Given this list of marker genes ZNF708, IRF2, GTF2H4, CDK2AP1, ABCD2, YWHAH, SNX24, TMEM60, ATP6V1A, STK26, ARHGEF6, INO80D, BORCS8, B3GALNT1, HEATR5A, RTN4, CD36, RNASE4, HMGA2, ATP6V1C1, METTL27, GPSM2, HPRT1, TMEM37, SKA2, TENT5A, NRP1, EIF3K, DLGAP5, CDT1, FOXO3, GPX3, TSPAN13, RASSF3, WIPF1, CASP8AP2, PHF14, SH2D3C, SHCBP1, SULF2, MED18, GNPDA2, MAPRE2, SLC41A3, CACUL1, SLC16A7, PEX3 (NCBI Gene Id 8504), YIPF6, CDKN2C, PANK1, GATC, PLEKHM1, NUCKS1, CEP44, MEF2A (NCBI Gene Id 4205), TMX4, FAM76A, TMEM135, UHRF2, GMNN, FBLIM1, RAD51AP1, GBA1, PSENEN, SASS6, NIPAL3, NOSTRIN, ANXA7, RBL1, RSF1, RBM15, METTL18, PLSCR4, ERMP1, RTF1, RBM43, GRAMD1B, ST3GAL5 (NCBI Gene Id 8869), CENPH, NCOA3, NUDT1, ANP32E, RDH10, TROAP (NCBI Gene Id 10024), RCBTB1, DRG1, LEPROTL1 (leptin receptor overlapping transcript like 1), MZT2B, CDCA5, C3orf70, PHKA2, HINT1, LRP1, RPL7A, PTP4A2, GABRR2, TPD52, EIF4B (NCBI Gene Id 55378), FBXW11, DIAPH3, C9orf85, SARS1, MAP3K5, COL14A1 (NCBI Gene Id 7373), ENC1, PADI2, IFT81, C2CD5, RAB40C, KIAA1143, GCNT1, SMARCAD1 (NCBI Gene Id 7303), MXD4, PDE7A, SUV39H1, FAM204A, ZNF496, DALRD3, CYP4F3, DRAM2, KIZ, SLCO4A1, CCDC47, AASDH, GCC2, OSBPL8, PALD1, MFSD12, NFATC2, SFT2D1, MPP1, TEC, ADSS2 (adenylosuccinate synthase 2), MYO1E, CBLB, NAP1L1, SNRNP25, RPL22L1, RCBTB2, ARHGAP19, HP1BP3, DYRK1A, HPF1, AGMO, FCHSD1, AKAP10, ANAPC1, CYP27A1, TRMT1, NDUFS2, FXYD5, ACD, EIF4A2, CD300C, CLIC4, CCR5, CHEK2, ARHGAP18, RBM41, DNASE1L1, DIPK1A, CCNDBP1, ARF6, CCR2, ACP6, SMIM30 (small integral membrane protein 30), ITGA6, FYN, CENPO, RHOBTB3, STRBP, PHF7, RGS18, CCND1, NCEH1, TFDP2, ZFAND4 (NCBI Gene Id 93550), BLTP3B, MIS18A, FAM107B, KDM2B, NUSAP1, CENPK, PRR11, ERCC6L, C1orf21, TNS3, H3C4, SELENOM, DGKZ, CCDC66, MTFR2, CREG1, TTC3, UBN1, EIF2D, POLG2, ATF6, MELK, ZNF467 (NCBI Gene Id 168544), here is a description of the gene set: studied in species Homo sapiens Human Gene Set: GSE24726_WT_VS_E2_2_KO_PDC_UP from publication Ghosh HS, Cisse B, Bunin A, Lewis KL, Reizis B (PMID 21145760) Genes up-regulated in plasmacytoid dendritic cells: wildtype versus TCF4 knockout. The interferon-producing plasmacytoid dendritic cells (PDC) share common progenitors with antigen-presenting classical dendritic cells (cDC), yet they possess distinct morphology and molecular features resembling those of lymphocytes. It is unclear whether the unique cell fate of PDC is actively maintained in the steady state. We report that the deletion of transcription factor E2-2 from mature peripheral PDC caused their spontaneous differentiation into cells with cDC properties. This included the loss of PDC markers, increase in MHC class II expression and T cell priming capacity, acquisition of dendritic morphology and induction of cDC signature genes. Genome-wide chromatin immunoprecipitation revealed direct binding of E2-2 to key PDC-specific and lymphoid genes, as well as to certain genes enriched in cDC. Thus, E2-2 actively maintains the cell fate of mature PDC and opposes the “default” cDC fate, in part through direct regulation of lineage-specific gene expression programs.